The following is a description of a gene set: species: Mus musculus Any process that increases the rate, frequency or extent of the formation of a lamellipodium, a thin sheetlike extension of the surface of a migrating cell. Mouse Gene Set: GOBP_POSITIVE_REGULATION_OF_LAMELLIPODIUM_ASSEMBLY, and this is the list of marker genes: Abi2 (abl interactor 2), Wasf2, Dnm2, Nckap1, Wnt1, Aqp1, Carmil2, Mstn, Actr3, Atp7a, Brk1, Hdac4 (histone deacetylase 4), Cyfip1, Mtor, Rac1, Rac2 (Rac family small GTPase 2), Plce1, Auts2, Twf2, Actr2, Arpc2, Cfl1, Avil, Hsp90aa1, Pik3r1, Akirin1, Frmd7, Clrn1, Fscn1, Cdc42